The following is a description of a gene set: Mouse Gene Set: GOBP_REGULATION_OF_FAT_CELL_PROLIFERATION species: Mus musculus Any process that modulates the frequency, rate or extent of fat cell proliferation., and this is the list of marker genes: Ppard, Tfdp1, Vstm2a, Per2, E2f1, Fgf16, Il4, E2f3, Fto, Pid1, Fgf10, Trem2, Ceacam2